Given this list of marker genes PMP22, HELLPAR, B2M, TONSL, CFH (complement factor H), CD46, CFI, here is a description of the gene set: Shoulder pain An unpleasant sensation characterized by physical discomfort (such as pricking, throbbing, or aching) localized to the shoulder. studied in species Homo sapiens Human Gene Set: HP_SHOULDER_PAIN